The following is a description of a gene set: species: Homo sapiens Adrenoceptors Human Gene Set: REACTOME_ADRENOCEPTORS, and this is the list of marker genes: ADRA1A, ADRA2B, ADRB3, ADRB2, ADRA2C, ADRA1B, ADRB1, ADRA2A, ADRA1D